Given this list of marker genes Mad2l1, Cep83, Pkhd1 (NCBI Gene Id 98273), Misp, Pard3 (par-3 family cell polarity regulator), Pard3b, Pafah1b1, Fhod1, Dlg1, Ezr, here is a description of the gene set: species: Mus musculus The directed movement of the centrosome to a specific location. Mouse Gene Set: GOBP_ESTABLISHMENT_OF_CENTROSOME_LOCALIZATION